Given this list of marker genes TST, TSTD1, SUOX, ETHE1, SLC25A10, SQOR, here is a description of the gene set: Human Gene Set: REACTOME_SULFIDE_OXIDATION_TO_SULFATE Sulfide oxidation to sulfate studied in species Homo sapiens